The following is a description of a gene set: Human Gene Set: CUI_DEVELOPING_HEART_ENDOCARDIAL_CELL from publication Cui Y, Zheng Y, Liu X, Yan L, Fan X, Yong J, Hu Y, Dong J, Li Q, Wu X, Gao S, Li J, Wen L, Qiao J, Tang F (PMID 30759401) studied in species Homo sapiens, and this is the list of marker genes: MYL7, SRPX, ATP1B1, PGAM2, CDH11, ANGPTL4, ENG, NT5E, LEPR, QSOX1, POSTN, IRX3, F2RL2, KLHL4, ITGA8, LRIG3, SCARA3, ISYNA1, COL18A1, CLEC11A, MYH6, EMILIN1, ST6GAL1, TMEM100, MEST, OST4, MASP1, ADGRG6, COLEC11, DSG2, NPR3, EPS8 (EGFR pathway substrate 8, signaling adaptor), PLA2G5, CTHRC1, PLVAP (plasmalemma vesicle associated protein), BMPER, ITM2C, EPHA4, ST6GALNAC3, NPPA, KRT18, TMEM141, FOXC1, IL33, PLAC9, PCDH7, ENPP1, NICOL1, SMOC1, CGNL1, FXYD6, OLFML3, TFPI